The following is a description of a gene set: species: Homo sapiens Human Gene Set: HP_ABNORMALLY_OSSIFIED_VERTEBRAE Abnormally ossified vertebrae An abnormality of the formation and mineralization of one or more vertebrae., and this is the list of marker genes: TRAPPC2, WDR35, ALPL, DYNC2I1, DYNC2I2, HSPG2, RMRP, BMPER, LFNG, COL11A2, EBP, LEMD3 (NCBI Gene Id 23592), IFT80, TBX4, LBR, SOX9, SLC26A2, VPS35L, TRIP11, INPPL1, RNU4ATAC, WNT3, NKX3-2, DYNC2H1, COL2A1, RSPO2, FLNB